The following is a description of a gene set: Mouse Gene Set: GOBP_POLYOL_TRANSMEMBRANE_TRANSPORT species: Mus musculus The directed movement of polyols, any polyhydric alcohol, across a membrane., and this is the list of marker genes: Slc26a6, Aqp7, Aqp9, Aqp3, Aqp11, Aqp2, Aqp1